Given this list of marker genes MRPL10, SNAP25, IL20RB, TDO2, TBL2, EIF4H, YWHAG, STYXL1, BUD23, DSEL, C1QTNF3, TUBA3E, PLOD1 (NCBI Gene Id 5351), here is a description of the gene set: Fumarate hydratase-deficient renal cell carcinoma (FH-deficient RCC) is a rare yet highly lethal kidney cancer. To deepen understanding of FH-deficient RCC, the authors conduct a comprehensive integrated genomic study. The authors analyze the association of FH alteration patterns with tumor heterogeneity and develop a CpG site-specific methylation signature for precise identification of FH-deficient RCC. Transcriptomic analysis unveils three distinctive molecular subtypes characterized by enrichment of immune/Angiogenic/Stromal (C1), WNT/Notch/MAPK (C2), and proliferation/stemness (C3) pathways, respectively. Tumors in C1 derive the most substantial survival benefit from a combination of immune checkpoint blockade (ICB) and anti-angiogenic therapy. Tumors in C2 display moderate response to this therapeutic approach. In contrast, tumors in C3 exhibit an unfavorable response to anti-angiogenic monotherapy and its combination with ICB. These findings contribute to a profound understanding of the aggressive nature of FH-deficient RCC, offering insights into potential precision medicine approaches for disease management. Human Gene Set: ZHANG_FH_DEFICIENT_RCC_C3_VS_OTHERS_UP studied in species Homo sapiens Genes upregulated in the C3 subtype of FH-deficient RCC relative to C1 and C2 subtypes. from publication Zhang X, Zhao J, Yin X, Liang J, Wang Y, Zheng L, Tan P, Lin Y, Xu N, Zhu S, Chen J, Zhao J, Hu X, Pan X, Nie L, Zhang M, Chen Y, Zhang Y, Liu H, Dai J, Wang Z, Liu H, Ni Y, Rupp NJ, Moch H, Sheng X, Gong K, Liu X, Chen Z, He Z, Wang Y, Xu L, Liu M, Zhou H, Tang B, Huang R, Wei Q, Li X, Liu J, Yao J, Liao B, Liu Z, Shen P, Chen N, Zeng H, Sun G (PMID 40355427)